Given this list of marker genes COL4A1, DMD (NCBI Gene Id 548327), THBS1, LAMB2, ACTB, DDR2, COL11A2, SNTB2, ITGB3, COL5A2, LAMB1, ACTN1 (NCBI Gene Id 87), ITGA2, SGCE, LAMA4, DTNA, ACTA2, COL11A1, LAMC2, LAMA2, FN1, TRAPPC4, DDR1, TGFB1, COL1A2, DRP2, CASK, SGCG, COL5A1, ITGAV, ACTG1, PDGFB, SNTG2, PRKCA, FGF2, COL10A1, SDC2, ITGB1, ITGB4, ITGA6 (NCBI Gene Id 3655), COL1A1, SDC1, COL2A1, LAMB3, DTNB, COL4A5, ACTA1, SDC3, LAMA5, ITGB5, VTN (NCBI Gene Id 7448), LAMA1, DAG1, SGCB, SNTA1, TNC, ACTG2, SGCZ, COL5A3, ACTC1, SGCA, NRXN1, LAMA3, COL4A2, TTR, SNTB1, LAMC3, COL3A1, SDC4, NTN4, SGCD, AGRN, LAMC1, COL4A4, COL4A6, HSPG2, SSPN, PDGFA, UTRN, COL4A3, here is a description of the gene set: Several non-integrin membrane proteins interact with extracellular matrix proteins. Transmembrane proteoglycans may associate with integrins and growth factor receptors to influence their function, or they can signal independently, often influencing the actin cytoskeleton. part of: Extracellular matrix organization species: Homo sapiens Reactome Pathway: Non-integrin membrane-ECM interactions